The following is a description of a gene set: from publication Lin JX, Li P, Liu D, Jin HT, He J, Ata Ur Rasheed M, Rochman Y, Wang L, Cui K, Liu C, Kelsall BL, Ahmed R, Leonard WJ (PMID 22520852) Human Gene Set: GSE36888_UNTREATED_VS_IL2_TREATED_TCELL_17H_DN studied in species Homo sapiens Genes down-regulated in T cells: control versus IL2 stimulation for 17h. Cytokine-activated STAT proteins dimerize and bind to high-affinity motifs, and N-terminal domain-mediated oligomerization of dimers allows tetramer formation and binding to low-affinity tandem motifs, but the functions of dimers versus tetramers are unknown. We generated Stat5a and Stat5b double knock-in (DKI) N-domain mutant mice that form dimers but not tetramers, identified cytokine-regulated genes whose expression required STAT5 tetramers, and defined consensus motifs for dimers versus tetramers. Whereas Stat5- deficient mice exhibited perinatal lethality, DKI mice were viable, indicating that STAT5 dimers were sufficient for survival. Nevertheless, STAT5 DKI mice had fewer CD4+CD25+ T cells, NK cells, and CD8+ T cells, with impaired cytokine-induced proliferation and homeostatic proliferation of CD8+ T cells. DKI CD8+ T cell proliferation following viral infection was diminished and DKI Treg cells did not efficiently control colitis. Thus, tetramerization of STAT5 is dispensable for survival but is critical for cytokine responses and normal immune function., and this is the list of marker genes: PLEKHA3, TUBB4B, MAML2, NEFH, CDKN2D, MSANTD3, SLC7A7, FPR2, LINC03025, MT1M, MT1F, S100A2, ADM, PLAC8, PLSCR1, LAIR1, PTGES, ACP2 (NCBI Gene Id 96117), SAMSN1, CLEC4E, CASP5, PSMB7, ZBTB17, INSIG2, SLC16A6, FUT8, NOL4L, TMEM45B, PLAGL2, PI4K2B, FCER1G, FTH1, TOM1, WNT5A, PDLIM7, CXCL6, ETV3, CYP27B1, CCL23, ANKRD33B, SPRED2, ACSL1, BCL2A1, FNDC3B, ELOVL7, ST20-AS1, FJX1, HS3ST3B1, FIGNL1, TLR2, PKM, AFDN, HCK, SH3PXD2B, ZNF697, IL15RA, FERMT2, SOD2, P2RY2, SERPINA1 (NCBI Gene Id 5265), KCNJ15 (potassium inwardly rectifying channel subfamily J member 15), ACOT9, BATF, NAMPT, TUBB, LAMB3, FCAR, ASPHD2, PTGS2, MN1, PNMA1, G0S2, CXCL2, DENND3, RCN2, PRKAG2-AS2, SLX4, DCUN1D3, ACKR3, TREM1, GK, TECPR2, HRH1, ZC3H12A, TNFAIP3 (NCBI Gene Id 7128), PVR, CYSTM1, ADGRE2, CCM2L, TRAF1, FSD1L, SOCS2, TRIP10, UFD1, MT1X, SPACA6, RFTN1, IER5, PIK3AP1, DNER (delta/notch like EGF repeat containing), NDP (NCBI Gene Id 4693), H2BC4, TGFA, NFKBIZ, CD274, TMEM115, CXCL1 (NCBI Gene Id 2919), MFSD2A (NCBI Gene Id 84879), PLAUR, NFAT5 (nuclear factor of activated T cells 5), C15orf48, SLC7A11, HLX, LIMK2, CYRIA, TUBB2A, ZNF319, ANKRD22, IL6, SOCS1, LDHA, CNIH4, BMAL2, GCH1, SMPDL3A, CISH, TBC1D16, CKAP4, GK5, LYN, MAP3K4, CA12 (carbonic anhydrase 12), CXCL3, LPP-AS2, MIR155HG, ZNF207, N4BP1 (NCBI Gene Id 9683), TP53INP2, TRAF3IP2, CDC42EP2, AZIN1, TNFRSF9, CD59, TNIP3, GPR68, TNFAIP6, CCL20, SLC41A2, MT2A, BCL6, S100A12, STK3, ITGB8 (NCBI Gene Id 3696), SGPP2, SLC25A37, HECW2, RILPL2, LILRB1, ATP13A3, PTX3, DDIT4, MIR23AHG, SLC39A8, ETV5, GALNT4, CYB5R2, BBIP1, GLRX, MT1E, HAS1, CLIC1, GNA15, BEST1, STX1A, MIR3945HG, MET, CPD, BTG3, VDR, HMGN2P46, NFKB2 (nuclear factor kappa B subunit 2), CCL4, GLIS3, ACVR1B, ICAM1, ASAP1, TBC1D30, ATP2C1, ALOX5AP, CXCL5, PLP2, PSD3, AK4 (adenylate kinase 4), MCOLN2, PFKFB3, KYNU, TUBB3, KIF3B, TNIP1, PLGRKT